Given this list of marker genes MMP13, GUSB, GPR146, RRAGA, PRNP, CERS4, STARD4, FADS3, MEST, SEPTIN6, S100A16, GZMH, COL4A1, PEX14, CD36, DGAT2, PGP, PMPCB, SRPRB, TOR1AIP2, GPSM2, FKBP4, EPHX2, P3H4, KANK3, IRS1, HMGCR, SNAI1, CA3, FDPS, ATP6V0A1, UNG, SLC41A3, PDLIM1, ACADVL (NCBI Gene Id 37), PLIN2, IDH3A, MAP2K3, CLDN15, PPP1CA, RRM2, ALCAM, RASAL2, RNF19B, TDRD7, TCF7L2, CIB2, TMED8, SGMS1, DENR, COL15A1, MSN, COL6A3, HADHA, PLAT, TALDO1, FDX1, CAPN6, PLK1, HADHB, FKBP10, NR3C1, NADK, ACOX1, PIM3, MGST3, GHRH, IL10RA, CS, ADIPOQ, NT5C2, SLC4A7, ATL3, TSPAN9, NUDT4, ACSS2, PALLD, GSN, PDE2A, PPA1, C1GALT1, HDAC6, COL6A2, INHBA, FOXK1, LRRK1, PPCS, CYP2F1, DGAT1, C9orf72, HSDL2, PEBP1, SERPINH1, FGFRL1, ARC, LPCAT3, ACLY, PRG4, ULK2, XIAP, KRT20, NPPC, TUBB6, CBR3, ABHD12, NFE2L3, LPO, SPRYD3, SRXN1, PDE4A, MMP19, METRNL (meteorin like, glial cell differentiation regulator), NUP210, PNPLA2, DUSP1, BOP1, ACO2, FSTL3, SEMA3E, CRTAM, SERPINE1, PLK3, SCIN, RAMP1, CIDEC, ZMIZ1, STXBP4, MRPL10, LIPA, PC, UGT2B10, NPR2, LCOR, KRT18, EGLN3, MCRIP2, PLAUR, ECH1, PTGR2, RRAS2, GALE, PITPNB, UBE2D3, ANXA2, TMEM134, UCP2, EHD2, FABP4, PSMF1, ATF7, DHX40 (NCBI Gene Id 79665), MGAT4B, ZC3HC1, GSPT1, ACADL, SMPD1, PDK4, CDK18, FHDC1, ACBD3, HIF1A, UBD, SORBS1, GRIP1, PDCD1, ERMP1, CTSC, TSPY1, RNF214, TNFRSF21, PARM1, PCSK7, ATP6V1A, PEG10, LPL, PLVAP, HAS2, CMPK1, NOMO1, TMEFF1, LIG3, RGS8, COL11A2, HOXB3, CITED1, IL17RC, PDE1B, APLP2, SCARB1, FGF2, EXOC6, PTGS1, TUBB4B, VEGFA, DNAJA4 (DnaJ heat shock protein family (Hsp40) member A4), AKR1B1, LAS1L, ABCB1, SLC45A3, LXN, here is a description of the gene set: Genes down-regulated in monocyte-derived dendritic cells: untreated versus LPS and LPS like antigen from O. planktothrix (3h). studied in species Homo sapiens Human Gene Set: GSE4748_CTRL_VS_LPS_AND_CYANOBACTERIUM_LPSLIKE_STIM_DC_3H_DN A cyanobacterial LPS antagonist prevents endotoxin shock and blocks sustained TLR4 stimulation required for cytokine expression. We report the identification and biologic characterization of an LPS-like molecule extracted from the cyanobacterium Oscillatoria Planktothrix FP1 (CyP). from publication Macagno A, Molteni M, Rinaldi A, Bertoni F, Lanzavecchia A, Rossetti C, Sallusto F (PMID 16717116)